The following is a description of a gene set: Binding to a sialic acid, a N- or O- substituted derivative of neuraminic acid, a nine carbon monosaccharide. Sialic acids often occur in polysaccharides, glycoproteins, and glycolipids in animals and bacteria. studied in species Mus musculus Mouse Gene Set: GOMF_SIALIC_ACID_BINDING, and this is the list of marker genes: Siglech, Cd22, Mag, Sele, Fcnb, Siglecl2, Selp (selectin, platelet), Siglecf (NCBI Gene Id 233186), Siglecg, L1cam, Sell, Agrn, Cd33, Adipoq, Siglece